The following is a description of a gene set: Human Gene Set: GOCC_EXOCYTIC_VESICLE species: Homo sapiens A transport vesicle that mediates transport from an intracellular compartment to the plasma membrane, and fuses with the plasma membrane to release various cargo molecules, such as proteins or hormones, by exocytosis., and this is the list of marker genes: SYT1, PPFIA2 (PTPRF interacting protein alpha 2), MCTP2, VPS45, SLC17A8, NGF, VAMP1, TMEM230, LGI3, RAB11B, STON1, PTPRS, ATP6V0A4, TMED9, SVOP, SYPL2, VTI1B (vesicle transport through interaction with t-SNAREs 1B), MTMR2, STX16, SYN2, NKD2, ATP6V1G1, SEPTIN8, NTF4, SYTL2, PARK7, RAB13, AP2M1, PSEN2 (presenilin 2), SYT12, SLC35G2, RPH3A, SYT10, DMXL2, RAB40C, RAB8A, GABRA2, CPLX3, IGF1, MYOF, MCTP1, SYT6, SYNPR, APP, SLC18A2, CDK16, OTOF, TPRG1L, SCAMP1, SLC32A1, COPS4, SNAP25, SLC6A2, ATP6V0E2 (NCBI Gene Id 155066, ATPase H+ transporting V0 subunit e2), SYT2, UNC13A, PHF24, RABAC1, PDE4B, CLCN3, BRSK1, CLTB, SYTL4, SYT11, NCSTN, KIF1B, RAB27A, RAB3B, SYNGR2, LRRK2, BIN1, PTPRN2, SNAP91, SNAPIN, ZNRF1, SLC17A7, CTTNBP2, SLC5A7, GIPC1, RAB8B, ATP6V1A, SLC30A10, STX10, GABBR1, AMPH, ATM, GRIN1, DRD2, VAMP2, SLC17A6, MME, DISC1, SV2A, SLC35F1, PENK, HAP1, TRIM9 (NCBI Gene Id 23206), BTBD8, TAFA4, ANP32E, DLG4, RAB40AL, STXBP5, BACE1, UBE3A, DPYSL3, RNF112, OPRD1, DGKI, SYT8, SV2B (synaptic vesicle glycoprotein 2B), BDNF, ATP6V1D, SV2C (NCBI Gene Id 22987), KCNK9, PPT1, SYT5, RAB5B, ATP6V0A1, BORCS5, ATP8A1, CLCN4, SLC18A1, LAMP1, ATP6AP1, APBA1 (NCBI Gene Id 320), DNM1L, AP2B1, PRKN, CLN3, APH1A, SLC40A1, ATP6V0D1, UNC13C, MT3, SLC2A13, PRRT1, TMEM163, DNAJC5, STX7, PRRT2, TSNARE1, ATP6V1C1, SLC30A3, SLC6A9, RAB3C, PTPRN, RAB6A, SYT9, ARPC2, AP3S2, CLTA, RAB40A, DYSF, SLC17A5, ROGDI, SEPTIN6, SYT3, STX12, SEMA4C, SLC18B1, GPR151, RAB3A, RAC1, ATP6AP2, VTI1A, RAB3D, STX6, SYT13, STON2, ATP6V1B2, SLC18A3, CALM3, WFS1, RAB11A, DTNBP1, HCRT, ATP6V1G2, SEPTIN1, SLC6A17, SYTL5, SLC9B2, PICALM, SYN1, SLC35D3, SNCAIP, SEPTIN4, PICK1, CBARP, RAB12, ATP6V1H, ATP6V1B1, SYPL1, DOC2A (double C2 domain alpha), AP3M2, SYT17, SYTL1, SYT4, CLCN5, NDEL1, PSEN1, RAB40B, MFF, RAB27B, SYNGR4, RAB26, ATP2B1, TRAPPC4, RAB7A, ATP6V1G3, CACFD1, SLC2A8, BCL2L1, SYT15, STX1A, ATP6V1E1, UNC13D, TOR1A, LAMP5, GRIN2A, BSN, UNC13B, GRIA1, SLC4A8, SCAMP5, SYNGR1, KIRREL3, RAB10, NTF3, ICA1, TH, IQSEC1, ATP6V0C, SYTL3, SEPTIN5, ABCC8, AP2A1, PHAF1, SYNDIG1, RAB5A, AP1B1, SYP, SYN3, COPS5, FER1L5, SNCA, ANXA13, OPRK1, SYT7, SYNGR3, ATP6V1F